The following is a description of a gene set: Genes containing one or more binding sites for (Brd3) in their promoter regions (TSS -1000,+100 bp) as identified by GTRD version 20.06 ChIP-seq harmonization. species: Mus musculus Mouse Gene Set: BRD3_TARGET_GENES from publication Yevshin I, Sharipov R, Kolmykov S, Kondrakhin Y, Kolpakov F (PMID 30445619), and this is the list of marker genes: Cdadc1, Snx14, Rdm1, Scarb1, Gm26812, Gm8357, Nelfcd, Itpkc, Ccpg1 (NCBI Gene Id 72278), Fosb, Fbf1, Sft2d1, Gadd45g, Tonsl, 2610020C07Rik, Zfp318, Rnu7, Zfp457, Gle1, Ccdc17 (coiled-coil domain containing 17), Scarna2, H2bc15, H4c8, 4632411P08Rik, Pop4, G3bp2, Lmf1, Szt2, Bckdha, Smad6, Tbc1d22b, Kat14, Mettl14, Magohb (NCBI Gene Id 66441), Trpm8, Kiz, Neil3, mt-Th, Farsa, Chd2, Rab24, Anxa11, Nfe2, Mtmr14, A930006K02Rik, Sap30bp, Atg14, Vps35l, Setdb2, Cisd1, Eprs1, Kctd10, H2ac8 (H2A clustered histone 8), Sf3b2, Cs, Coa6 (cytochrome c oxidase assembly factor 6), Ptbp1, Bag5, Ctnnbl1, Mrpl37, Prpsap2, Ss18l2, Kifc1, Sf3a3, Spsb1, Lsm2, Stmn1, Cdk18, H4c16, Szrd1, Cdc25c, Pithd1, Ankzf1, Nup93, Ptprn2, Serhl, Entpd3, Vdr, Gcdh, Dus1l, Dcdc5, Max, Cgas, Gm43391, H2ac6, Cd37, Rps13, Wdtc1, Cox17, Malat1, Gm23969, Ndufb5, 4930506C21Rik, Prelid1, Snord14a, Mtmr6, Gfm2, Mplkip, Chaer1, Gm11175, Gpatch11, Gm15454, Gm10222, Cdc42bpg, Kri1, Fkbp2, Ints8, Rpl6, Rbm19, Mcur1, Nsmf, 1110059G10Rik, Mcoln1, Rock1, H2ac11, Zfand1, Sub1, Grb2, Lnpk, H2bc8, 1810055G02Rik, Tmem250, Aunip, Gfod2, Recql5, Gm16675, Cggbp1, Gm4117, Ddx17, Tmem217 (NCBI Gene Id 71138), Ndufs2, Mtmr3, Tpra1, Rell1, Ano7, Lrpap1, Pitpnb, Cab39l, Surf2, Ffar4, Zfp473, Ltn1, Prkrip1, Dgkz, Cage1, Aasdhppt, Paip2, Itpr3, Wdr45b, Wipi2, Slc17a5 (NCBI Gene Id 76855), Arf4, Uqcr11, Ube3b, H4c6, Gm13270, Supt4a, Grcc10, Gm15564, Tlcd1 (NCBI Gene Id 68385), 2610005L07Rik, Il6st, Avpi1, Sh3gl1, Snx8, 3300002I08Rik, Cstpp1, Smad4, Alg9, Fancl (NCBI Gene Id 78872), Kif15, Gm17138, Mtbp, Mpv17, Mfap3, Cmtm6, Gtf3c6 (general transcription factor IIIC, polypeptide 6, alpha), Srgn, Acad11, Nos2, Mapk8ip3, Zfp866, Fuca1, Zfpl1, Irf2, Med8, Eml4, Ttc39d, Msantd7, M6pr, Gm13073, Rpl7l1, Calr, Epg5, Tti2, Polr2k, Kif20a, Aars2, Kif18a, Abhd1 (NCBI Gene Id 57742), mt-Tm, Gins2, A430072P03Rik, Glod4, Exosc4, Dhdds, Atp13a1, Rpn1, Ccp110, Sugct, Rsrc2, Gen1, Matcap2, Mkrn2, Abce1, Tmem25, Utp6, Limk2, Twf2, Bap1, Cebpzos, Spint2, Tmx1, Ppdpf, Zfp623, Duxf1, H1f3, Nsun3, Zfand2a, Usp47, Fam220a, Adam8 (NCBI Gene Id 11501), Nup133, Ccny (NCBI Gene Id 75537), Trap1, Baz1a, mt-Tl2, Kifap3, Pter, H1f2, Phf7, Miga2, Alyref2, Hk1, Sh3bp2, Ggnbp1, mt-Nd2, Fam216a, Rab14, B4galt3, Ptgr2, Dnajc16, Slc29a3, Coa5, Psen1, Gm15612, Cript, Golga7, Mms22l, Pepd, mt-Tl1, Unc50, 2310044K18Rik, Atp5mj, AU020206, Gm4152, Pik3r1 (NCBI Gene Id 328326), Cpt2, Dcp1a (NCBI Gene Id 75901), Ndor1, Coa8, Lrrc40, Shoc2, Ubiad1, Sesn2 (sestrin 2), Kbtbd3 (kelch repeat and BTB (POZ) domain containing 3), Snord118, Nat10, Helb, Vps52, Gm10614, Eapp, Prr14l, Rfc2, Col1a1, Tnfsf13, Anapc5, Cux1 (cut-like homeobox 1), Lss, Brd10, Rps14, Scamp2, Poldip3, Aff1, Dusp11, Tmem87a, Tfrc, Mrpl13, Scfd1, Tex30, Wipf2, Ints9, Grhpr, Mknk2, Ppp1r8, 6030443J06Rik, Fbxw7, Pinx1, Srsf7, Papolg, Ptma, Rsu1, Bmal2, Lmbr1, Anapc10, Abhd4, Surf1, Jag1, Etf1, mt-Ti, mt-Nd1, Acadm, Pomp, Gm26511, Mus81, Rsl1d1, Rnf123, Kntc1, Hlx, Mir6236, Fbxl19, Phf19, mt-Nd5, A930016O22Rik, Nsa2, Med6, Cpsf6, Capn3, Brd8, Cox7a1, Rab13 (RAB13, member RAS oncogene family), Papss1, Tspo, Rida, Commd9, Acaa1a, Mcm2, Dimt1, Rps27, Slx4, Gm14455, Clcc1, Washc2, mt-Rnr2, Vps33a, Plxnb2 (plexin B2), Washc1, Tmem230, Diaph1, Meiob, Pde4dip, Ddx42, Ctdsp1, Midn, Arl5b, Mtch1, Fxr2, C3, Cog8, Dtymk, Slc39a1, Gba1, Pxn, Tmem183a, Arpc5l, Ilrun, Zfp719, Zkscan8, Nme3, Ppp1r15b, Smarcd2, Hspa9, Mrps35, Gfi1, Grk4, Ddx21 (DExD box helicase 21), Apmap, Mical2, Mpp4, mt-Ts2, Mst1 (NCBI Gene Id 15235), Ccdc47, Gm26205, Ccdc12, Chmp7, Ccdc97, Smim6, Gpn3, mt-Tv, Tex14, 1700120C14Rik, Gm26306, Cdca5, Gm10501, Pdcd11, Ufsp1, Arf2, Med28, Adrb2, Metap1d, Ttc1, Poli, Pet117 (PET117 homolog), Mrm3, Exosc5, Gosr1, Hjurp, Pafah2, Snf8, Cnot8, Med22, Mturn, Rnf220, 5430416N02Rik, Tmem135, Abtb1, Crybg2, Myl6, Atg2b, Qtrt2, Ostc, Pdss1, Herpud1, Gse1, Taf13, C530005A16Rik, Ipo9, Dmwd, Dnajc24, Nop14, Fam8a1, Napepld, Dcakd, Ccar1, Snupn, Hk1os, Flnb, Arhgap21, Nsun6, Fbxl2, Ganc, Zfp87, Rpl7a, Kmt2a, Colgalt1, Tut7, Rpl10a, E230029C05Rik (RIKEN cDNA E230029C05 gene), Gatd3a, Wdfy4, Zfp696, Zbtb9, H2ac15, Rbpj, Ccdc174, Hmbox1, H4c11, 4930445N08Rik, Ufm1, Rpl23, Pnkd, Spata31e2, Fam136a, Adat1 (NCBI Gene Id 30947), Amn1, Gm11335, Gm16046, Osgin1, 2010110K18Rik, Speer4cos, Dad1, Gm25939, Heatr5b, Tmem267, Vrk3, Atp5mk, Cdnf, Aamp, Eif2ak1, Eed, Kcnt1 (potassium channel, subfamily T, member 1), Cdpf1, Snora21, Aak1, Gskip, Pi4kb, Trpm2, Coro7, Snx4, Lactb2, Snord13, Gpr157, Smpd4, Irx3, Fam114a2, Ccdc181, Tomm7, H2bc11, Mcrs1, Uba6, Bpi, Cyb5rl, Cops9, Cdc37, Orc5, Rrm2b, Cox15, Asb1, Uqcc1, Cyb5r4, Mettl15, 4930532G15Rik, Nfkbiz, Lcn2, Dis3, Mff, 1700122E12Rik, Irak2, Igsf9, Cdk5rap2, Copg1, Gm19265, Taf5, Necap2, Eif3l, Apoc1, Akirin2, Adgrg3, Pierce2, 3110070M22Rik, Mlxipl, Ccdc191, Irx3os, Cox16, Traip, Fam98a, Mcpt8, Ing1, Tent5a, Cdk20, Pigf, Rtf2, Rnu11, Atg9a